Given this list of marker genes SMURF1, UBA52, PRKCZ, RHOA (ras homolog family member A), TGFB1, RPS27A, F11R, CGN, UBC, ARHGEF18, PARD6A, FKBP1A, TGFBR1, TGFBR2, UBB, PARD3, here is a description of the gene set: Human Gene Set: REACTOME_TGF_BETA_RECEPTOR_SIGNALING_IN_EMT_EPITHELIAL_TO_MESENCHYMAL_TRANSITION studied in species Homo sapiens TGF-beta receptor signaling in EMT (epithelial to mesenchymal transition)